The following is a description of a gene set: Mouse Gene Set: MIR_1982_5P Genes predicted to be targets of miRBase v22 microRNA mmu_miR_1982_5p in miRDB v6.0 with MirTarget v4 prediction scores > 80 (high confidence targets). from publication Chen Y, Wang X (PMID 31504780) species: Mus musculus, and this is the list of marker genes: Csde1 (NCBI Gene Id 99530), Cfhr1, Cdk2ap1, Gdi1 (GDP dissociation inhibitor 1), Acsf2 (acyl-CoA synthetase family member 2), Mpz, Laptm5, Nf2, Fkbp10, S100a16 (NCBI Gene Id 99704), Usb1, Rbm4b, Elk1, Foxp4, Tfg, Calcr, Ftsj1, Zfp704, Trim52, Rcsd1, Atrn, Adam28, Cadm3, Zfp174, Stxbp4 (syntaxin binding protein 4), Tspan18, Foxk1, Fbln5, Hcfc1, Krtap2-20, Plec, Mip, Pim1, Ndst1, Eeig1, Nceh1, Pogz, Pou2f1, Stpg1, Shisa7, Kirrel3, Kcnip1, Sf1, Rbbp4, Fbxw2, Cxcr5, Cop1, Rab37, Sema4g, Inpp5b, Tead1, Agpat1, Vps25, Cyp2b10, Psmf1, Lrrc38, Chtf8, Runx1, Cyp2b13, Ring1, Bloc1s5, Ednra, Hoxa11, Rufy2, Sgcg, Atf7 (NCBI Gene Id 77354), Syt15, Arhgap9, Pianp, Srebf2, Aqp6, Thsd7a, Eif4ebp3, Klc2, Cdk5r2, Zfp275 (NCBI Gene Id 71402), Lck, Abcg4, Azi2, Ddx6, Stx5a, Cic, Coro2b, Rpap2, Zfp456, Vwa5b2, Tpm1, Col24a1, Cdsn, Abitram, Drg2, Arg1, Pde6d, Rnf40, Reep5, Usp30, Sdc3, Cyp2b9, Scamp2, Gnl3l, Cbx5, Samd4, Sec14l1, Zfp655, Helb, Nt5c3b, Plac8l1, Prr3, Ctdsp2, Slc2a4, Csdc2 (cold shock domain containing C2, RNA binding), Afap1, Trappc14, Kcnh4, Clec3a